The following is a description of a gene set: Mouse Gene Set: REACTOME_BRANCHED_CHAIN_AMINO_ACID_CATABOLISM species: Mus musculus Branched-chain amino acid catabolism, and this is the list of marker genes: Echs1, Ppm1k, Bckdha, Ivd, Auh, Mccc1, Bckdk, Aldh6a1, Dld, Bckdhb, Hsd17b10, Bcat2, Bcat1, Dbt, Mccc2, Acad8, Acadsb, Hibadh, Hibch, Acat1